Given this list of marker genes CHRNA2, FOLR3, GLRA1, CHRNA4, GLRA2, P2RX3, P2RX4, CHRNA7, FOLR1, CD14, GLRA3, CHRNB3, CHRNB1, CHRNA3, here is a description of the gene set: Human Gene Set: MODULE_328 species: Homo sapiens AcetylCholine receptors.